Given this list of marker genes H4C4, MYL9, H4C8, H3C10, H3C11, KMT2C, CBFB, H4C9, H4C15, ITGA2B, NR4A3, KMT2D, H3C8, H4C6, H2AC20, H3C14, MOV10, H2AZ2, H2AX, SETD1A, RBBP5, DPY30, H2BC9, H3C3, H2BC1, H2BC14, EP300, H3C12, PRMT6, H2AC18, H3C6, THBS1, PF4, H2AC6, H4C11, RUNX1, H2AB1, ASH2L, MIR27A, GP1BA, WDR5, H2AC4, HDAC1, SETD1B, H2BC12, H2AC8, H2BC17, SIN3A, H2BC4, ZFPM1, AGO1, H3C7, H3-3A, H3C4, H4C14, TNRC6A, H4C3, H2AC7, H3C2, H2BC15, H3C1, PRKCQ, H2BC7, H2AC14, H2BC26, H4C12, H2BC10, H2AJ, H2BC21, SIN3B, TNRC6B, H4C1, AGO4, H2BC11, KMT2A, GATA1, NFE2, TNRC6C, H3C13, H4C5, H2BC8, H2BC13, H2BC6, H2BC3, H2AC19 (NCBI Gene Id 723790), AGO3 (NCBI Gene Id 79910), H3-3B, H3C15, H4C13, H2BC12L, H2BC5, PRMT1, H4C2, H4C16, KMT2B, KAT2B, here is a description of the gene set: Human Gene Set: REACTOME_RUNX1_REGULATES_GENES_INVOLVED_IN_MEGAKARYOCYTE_DIFFERENTIATION_AND_PLATELET_FUNCTION species: Homo sapiens RUNX1 regulates genes involved in megakaryocyte differentiation and platelet function